The following is a description of a gene set: from publication Hu X, Park-Min KH, Ho HH, Ivashkiv LB (PMID 16148108) Genes up-regulated in macrophages stimulated by IFNG: 3h versus 24h. species: Homo sapiens Human Gene Set: GSE1925_3H_VS_24H_IFNG_STIM_MACROPHAGE_UP IFN-gamma transcriptional responses in control and IFN-gamma primed primary human macrophages, and this is the list of marker genes: SDC1, ACOT8, HYAL4, TCEAL2, OSGIN2, DEFA4, EVPL, IMPDH1, MRPS22 (mitochondrial ribosomal protein S22), NR3C2, PIM1, FAM184A, PLCG2, CCNB1IP1 (NCBI Gene Id 57820), TUBA1A, DUS4L, SLC22A1, CHRNA5, STAP2, OR2C1, ZNF253, SLAMF1, SI, KCNJ16, SLC6A14, CRYBB2P1, NSUN7 (NOP2/Sun RNA methyltransferase family member 7), SPIN1 (spindlin 1), PSMA1, PSMD8, ATP2B4, SEMG1, DKK4, THPO, TFF1, TFAP2A, SLC7A11, CPA2, DKK2, LRRC17, SGCB, PALM (paralemmin), SPTA1, TRPC4, GYPB, LIF, PIAS3, VTN, PRR14, RNF24, EPPK1, DNAI4, GS1-600G8.3, CCDC170, WNT16, DIRAS2, GOT1, DSTNP2, KCNJ15, CPA3 (carboxypeptidase A3), KIR2DL4 (killer cell immunoglobulin like receptor, two Ig domains and long cytoplasmic tail 4), ENAH, HBQ1, PDCD11, SVEP1, HEXA-AS1, CORO1C, GPX5, MEA1, GOT2, MTX2, NACC2, DARS1, ILVBL, CNOT1, PCCB, PRKAA1, PERP, DRAM1, LILRA1, NBR2, KIR2DS3 (killer cell immunoglobulin like receptor, two Ig domains and short cytoplasmic tail 3), MCM2, CDH13, SYNDIG1, MLH3, HSPA9, ZNF133, ARID5B, RFPL3, SNU13, RRAGD, ERAL1, CD40LG, CIDEC, DEFB126, MAGEA3, AKR1C2, TDP1, NF1, RADX, TNFRSF21, SH2D3C, PFN2, NEUROG2, TRIB3, CD163, KAT2A, JUN, COG5, ASCC1, NCK2, HTN3, GRP, RNMT, BFSP2, OR10H1, TMEM186, IFNG, NDUFA7, OR7E47P, GPR50, IPO5, PTPN1 (protein tyrosine phosphatase non-receptor type 1), CHML, H2AZ1, RPL10P17, HIP1, EMC9, DCX, AARS1, ZBBX, RING1, LTA4H (leukotriene A4 hydrolase), FLVCR2, DUOX1, MRPL22, ZKSCAN5, RARB, COL19A1 (NCBI Gene Id 7950), TPM1, TSBP1 (NCBI Gene Id 10665), EML1, SERPINB1, CEP104 (NCBI Gene Id 9731), INHBE, GRIK1, CASP9, UCP2, TBC1D22A, COA4, SLC27A6 (NCBI Gene Id 28965), ST13, H3C6, PNPLA4, FTL, ZNF500, LINC00390, GARNL3, PRPH2, PLIN2, TFCP2, ICA1, TTLL7, NDUFV2, TCL1A, RNF185, SLN, ST6GALNAC5, IL1RL1, INSL6, FKRP, ST3GAL6 (ST3 beta-galactoside alpha-2,3-sialyltransferase 6), FARP2 (FERM, ARH/RhoGEF and pleckstrin domain protein 2), HDHD5, IL18RAP, STON1, MED8, FAM149B1, MT4, DUSP1, IFNA1, VDAC2, RPS2, STX12, MYOZ2, TUFT1, LRRC37A4P, CYP19A1, NLE1 (NCBI Gene Id 54475), ACSL1, AKR1A1, KCNK15, STXBP6, ZDHHC18, STATH, RSPH14, FAM90A1